The following is a description of a gene set: Human Gene Set: MIR6864_3P from publication Chen Y, Wang X (PMID 31504780) Genes predicted to be targets of miRBase v22 microRNA hsa-miR-6864-3p in miRDB v6.0 with MirTarget v4 prediction scores > 80 (high confidence targets). studied in species Homo sapiens, and this is the list of marker genes: VSNL1, GASK1B, KAT6A, ARHGAP29, ZNF443, FXR1, HDAC9, RFLNB, USP22, PUM1, ABCB10, EIF4A2, ZNF662, CHL1, PLA2R1 (NCBI Gene Id 22925), MAP1A, MRPS18B, ANTXR1, RSPRY1, RPL13, ZBTB41, EMP2, RSKR, MTARC1, CNTN1, FRMPD4 (FERM and PDZ domain containing 4), BZW1, BMPR2, RBM8A, KIRREL1, ZNF331, MTCH2, CHRNA9, ETV5, EPB41L4A, CALCRL, CDK2AP1, HRH4, GPATCH2, USP15, POT1, RIMBP3B, STK39, KHDRBS2, SV2B, MAPK3, CCT6B